The following is a description of a gene set: studied in species Homo sapiens part of: Metabolism of amine-derived hormones Reactome Pathway: Serotonin and melatonin biosynthesis Serotonin (5-HT) is a hormone and neurotransmitter used for regulatory purposes in animal CNS. In the human brain, serotonin is involved in many physiological functions such as sleep, pain, mood and is the precursor to melatonin, a hormone produced in the pineal gland., and this is the list of marker genes: ASMT, TPH1, AANAT, TPH2, DDC (dopa decarboxylase)